Given this list of marker genes NFKBIL1, UBA1, LYN, C1QB, IL10, NCF4, PSMB4, SHARPIN, FAS, MIF, ERAP1, TREX1, PTPN22, KLRC4 (NCBI Gene Id 8302), CCN6, PRTN3, P4HA2, CASP10, TNFRSF1A, HLA-DRB1, RNF31, PRKCD, ADA2, SLC29A3, SAT1, CCR1, LPIN2, IL12A-AS1, IL23R, CARD10, IL37, LBR, TGFB1, ELF4, TLR4, IL36RN, PSMB8, MTTP, CIITA, ANKRD55, MEFV, ZNFX1, ARPC1B, HLA-B, LACC1, CD244, IFNGR1, UBAC2, HLA-DPA1, MYD88, PTPN6, IL12A, POMP, PTPN2, MVK, AP1S3, CD247, HLA-DPB1, IL6, SLC22A4, IL1RN, C4A, NLRP3, PLCG1, COPA, IL2RA, IL12B, IL1R1, IL2RB (interleukin 2 receptor subunit beta), NLRP12, IRAK1, MLX, NOD2, CTLA4, STAT4, ITK, STING1, SPP1, here is a description of the gene set: studied in species Homo sapiens Human Gene Set: HP_ABNORMAL_ERYTHROCYTE_SEDIMENTATION_RATE Abnormal erythrocyte sedimentation rate A deviation from normal range of the erythrocyte sedimentation rate (ESR), a test that measures the distance that erythrocytes have fallen after one hour in a vertical column of anticoagulated blood under the influence of gravity. The ESR is a nonspecific finding. An elevation may indicate inflammation or may be caused by any condition that elevates fibrinogen. A decreased ESR may be seen in polycythemia or in certain blood diseases in which red blood cells have an irregular or smaller shape that causes slower settling.